Given this list of marker genes Clec16a, Mylip, Mul1, Snca, Prnp, Fbxo4, Id1, Iapp, Siah1a, Senp2, Btrc, Ccdc88c, Hdac6, Derl1, Fbxw11, Chfr, Plk1, Gsn (gelsolin), Dazap2, Mtor, Rnf139, Ep300, Gga3, Isoc2a, Isoc2b, Htt, Bmp2, Igtp, Vps35, Rad23a, Crebbp, Cul3, Commd1, Cdkn2a, Cdc73, Kdm8, Serf2, Ctsh, Fbxw7, Irgm2, Siah1b, Src, Fbxl3, Irgm1, Rnf5, Nr1d1, Npm1, Utp25, Prkdc, Capn3, Sirt1, Mdm2, Serf1, Xbp1, Prkn, Pex2, Sox17, Trim21, Sirt6, here is a description of the gene set: Mouse Gene Set: GOBP_PROTEIN_DESTABILIZATION species: Mus musculus Any process that decreases the stability of a protein, making it more vulnerable to degradative processes or aggregation.